The following is a description of a gene set: Mouse Gene Set: GOBP_REGULATION_OF_TOOTH_MINERALIZATION Any process that modulates the frequency, rate or extent of tooth mineralization, the deposition of calcium salts in tooth structures. studied in species Mus musculus, and this is the list of marker genes: Dicer1, Enam, Amtn (NCBI Gene Id 71421), Slc4a2, Tgfb1, Bcor, Dmp1, Wnt6, Odaph, Cftr (NCBI Gene Id 547216), Tfap2a, Dspp, Aspn (asporin)